Given this list of marker genes XDH, PNP, NT5C2 (NCBI Gene Id 22978), NT5C, NT5C1A, here is a description of the gene set: species: Homo sapiens Human Gene Set: GOBP_IMP_CATABOLIC_PROCESS The chemical reactions and pathways resulting in the breakdown of IMP, inosine monophosphate.